Given this list of marker genes FIBCD1, TFAP2A-AS1, TLK2P1, MEIS2, RCN1, RPS29P24, ZNF385C, GRPR, GRM8, FRMD5, TFAP2E, VPS41, PRDM13, GABRG1, PIN4P1, MIR181A1HG, SAMTOR, ASIC2, LINC00871, CPNE6, RGS8, ADCY8, MCHR2-AS1 (MCHR2 antisense RNA 1), DRD1, C1QL2, here is a description of the gene set: Marker genes curated from the annotated cluster as represented in the Descartes Human Gene Expression During Development database. Human Gene Set: DESCARTES_MAIN_FETAL_AMACRINE_CELLS The gene expression program underlying the specification of human cell types is of fundamental interest. The study authors generated human cell atlases of gene expression and chromatin accessibility in fetal tissues. For gene expression, the study authors applied three-level combinatorial indexing to >110 samples representing 15 organs, ultimately profiling ~4 million single cells. The study authors leveraged the literature and other atlases to identify and annotate hundreds of cell types and subtypes, both within and across tissues. Our analyses focused on organ-specific specializations of broadly distributed cell types (such as blood, endothelial, and epithelial), sites of fetal erythropoiesis (which notably included the adrenal gland), and integration with mouse developmental atlases (such as conserved specification of blood cells). These data represent a rich resource for the exploration of in vivo human gene expression in diverse tissues and cell types. species: Homo sapiens from publication Cao J, O'Day DR, Pliner HA, Kingsley PD, Deng M, Daza RM, Zager MA, Aldinger KA, Blecher-Gonen R, Zhang F, Spielmann M, Palis J, Doherty D, Steemers FJ, Glass IA, Trapnell C, Shendure J (PMID 33184181)